The following is a description of a gene set: Human Gene Set: MIR524_5P from publication Chen Y, Wang X (PMID 31504780) Genes predicted to be targets of miRBase v22 microRNA hsa-miR-524-5p in miRDB v6.0 with MirTarget v4 prediction scores > 80 (high confidence targets). species: Homo sapiens, and this is the list of marker genes: PLEKHG1, FAM3C, CDH15, CCT7, ARFGEF3, RIF1, SUMO1, HS3ST3B1, MAPK6, TRDN, PDE10A, PSMB9, SMAD2, CTHRC1, SMC4, DNTTIP1, LIPA, UBE2D3, TUBB2B, RRAS2, SC5D, NRK, MED4 (mediator complex subunit 4), SEC24A, GOLGA6B, ARHGAP35, BSDC1, IGSF3, PTHLH, MECOM, ELK4, MAEL, WASHC4, SLC39A14, GIGYF2, NOP58, ANKRD44, MYF6, CHODL, SELENOF (selenoprotein F), DCAF7, WNK1, C11orf58, ST18, RNF182, CYP7B1 (cytochrome P450 family 7 subfamily B member 1), JAG1, RNF138, DCUN1D1, DLG2, TAF12, GBX2, ZBTB44, PLPPR4, PRPF39, TMEM215, ZNF772, CLNS1A, TMEM161B, GNB4, PPTC7, LRP12, ZNRF3, DGKE, SEC14L2, PPP3R1, JUN, MEIOC, STXBP5, FAM83B, CERT1, CERS6, HOXC8, HLCS, KDM6A, PLCB1, TSC22D2, SPRED1, ADAM23, DYRK1A, ZBTB7C, RBM26, GLS, UBE2Q2, FBXO45, MEAF6, PEX3, EDIL3, KIF1B, ARHGAP12, TAF8 (NCBI Gene Id 135763), PNN, GOLGA6C, CNOT8, TTC28, NEXMIF, AASDHPPT, RGCC, ANGPTL7, UBA6, HMGA2, SMURF2, FAM221A, SLITRK2, TXNL4B, KIF2A, GART, DLG5, NUP43, PRELID3B, LTN1, SMIM43, CNTNAP3, USF3, STAT4, MAPK1, VSIG10, L3HYPDH, RBL1, NXT2, CDK2, PCBP2, SIX4, RGS7BP, PKN2, ENPP4, TMEM196, DKK2, ATF2, BMP3, UBE2B, SGK3, CDC42BPB, RORA, SGIP1, CACNB2, ZMYM2, SCEL, TSHZ2, ITPR1, GRID2 (glutamate ionotropic receptor delta type subunit 2), GPC6, EPHA7, CEP350, BCL11B, SEC24B, PCDH9, CALB1, ACER2 (NCBI Gene Id 340485), ZCRB1, STXBP4, MPDZ, RBM27, HMGB3, CDH19 (cadherin 19), PRPF40A, MOSPD2, DHX40, TRAPPC13, FBXO32, SSB, PPP1R21, NFATC3, GSPT1, PHIP, GJB2, C17orf75, KLHL23, SHISA3, ATP2B2 (ATPase plasma membrane Ca2+ transporting 2), TBL1X, CNOT2 (CCR4-NOT transcription complex subunit 2), DDX17, RCAN2, SLC44A5, KLF4, SCN2A, USP53, LRP5, EML6 (NCBI Gene Id 649652), GRIN3A, ATMIN, HOOK3 (NCBI Gene Id 84376), EP400, TLCD4, GRM7, MRS2, EGLN1, PKDCC, ARPP19 (cAMP regulated phosphoprotein 19), OGA, MITF, APLN, DDX6, VIRMA, OLFM1, ELAPOR1, GPR180, ZNF827, ANO8, ZNF583, RHOT1, PHLDB1, RSBN1 (round spermatid basic protein 1), SRBD1, CEP120, GLRB, CCDC6, BCLAF1, RFC1, PREX2, ZBTB34, KAT6A, SLITRK6, LATS2, TAOK1, SLITRK4, TNKS2, PNISR, BRD4, FAM169A, HIRA, ARVCF, PARP8, NCOA1, KIN, E2F3, CAV2, SPTSSA, RBM39, ADGRL2, CPEB3, PPP5C, TBR1, LRRTM3, PRICKLE2, TMEM163, TMEM17, SCN3A, HOXB7, ZNF106, HCFC2, LUC7L2, FRMD6 (NCBI Gene Id 122786), PPM1L, IRX2, EGR1, FAM184A, YY1, RSPH4A, TFDP2, PELI2, ARHGAP33 (NCBI Gene Id 93092), MYOD1, SCAMP5, DDAH1 (dimethylarginine dimethylaminohydrolase 1), PRKCB, HSD17B13, ZMYND19, DIRAS2, FKBP14, SRSF10, PRKAB1, CSDE1, MGAT3, SESTD1, ZIC3, NUP37, TM4SF4, TSHZ1, MAP3K8, EGR4, YTHDC2, CIAO2A, SMAD3, IL1A, GOLGA8J, SOCS6, WIPF1, FAM13C, GIPC2 (GIPC PDZ domain containing family member 2), SLC1A2, YBX1, PTPN13, UBR5 (ubiquitin protein ligase E3 component n-recognin 5), COL4A1, DENND5B, ATP2B1, TMX4, PPP1R1B (NCBI Gene Id 84152), PRDX3, ARL13B, MIS18BP1, SEPSECS, CNTN1, ANKRD46, CCN1, SLC34A2, SLC6A6, DACH1, PLEKHF2, GNA13, DNAAF9, FAM76A, RNF220, TTN, GMFB, L3MBTL3, SULF1, NUDT4, BRD3, TMEM33, PIP5K1A, SPCS3, SLC30A6, NKRF, GORASP2 (golgi reassembly stacking protein 2), TAB2, HSF2, KIF5A, SMC3, SERPINB8, LRP8, TXNDC9, THOC3, PPP3CA, MEOX2, SPATA13, SCN8A, MLLT6, PER2, SIPA1L2, FKBP7, RAB6B, PAPOLG, CACNA2D2, ATAD2B (NCBI Gene Id 54454), ZMAT3, CNR1, MSS51, COL1A2, ACKR3, ZFC3H1, SULF2, CCNT2, FZD3, CYP20A1, RBFOX1, VAV3, COL11A1 (collagen type XI alpha 1 chain), LEF1, CBX3, APPL2, API5, PPFIA3, CPNE2, UBA3, OPA1, AKIRIN1, GOLGA8H, STK10, CHN2, PPP1R9A, CNRIP1, PBX1, AKAP11, MPRIP, PPP1R8 (protein phosphatase 1 regulatory subunit 8), MBNL1, GALNT7, HNRNPK, GPBP1, FBLN2, RNF216, SP3, ELAVL2, RPS6KA3, UBE2E3, STRBP, IFT70B, FGFR2, BMPR1A, MTM1, TMEM220, MAST4, RBBP5, MATCAP2, LHX6, ADAM10 (NCBI Gene Id 102), GOLGA8T, GDF10, RIN2, EED, GPM6A, RAB11A, HECTD1, CD46, SBF2, SORL1, TSNAX, CREB1, SLC25A13 (NCBI Gene Id 10165), CREM, GOLGA8R, MAP4K3, CDPF1, DCAF4L2, ZNF704, VPS13D (vacuolar protein sorting 13 homolog D), PNOC, NOVA1, GPR63, SOX8, ADCYAP1, ADAMTS5, ZMYND11, IMPA1, LAMC1, HSPA1B, HNF1B, NEBL, KPNA1, EBF2, SLC16A4, TMEM50A, ABRACL, H1-0, TRIP11, BHLHE40, MYRFL, RPS6KB1, SKIL, ARL5B, CHIC1, LIN9, SIRT1, PUS7, ZNF638, ZBTB43, GLUD1, ELOA, TRPS1, FZD2, BZW1, DICER1, ADAMTSL3, MAPK8, AZI2, TOM1L1, SRSF2, PRKRA, PSG1, MAMLD1, IKZF2, BCOR, SESN1, PPFIA1, KPNA4, KLHL28, ACSL3 (acyl-CoA synthetase long chain family member 3), DOCK1, TCF4, GNPTAB, RAI14, RAB14, TFRC, TCP11L2, CD1A, NEGR1, EOMES, SCAI, JMY, CENPC, CADM2, SUB1, SIPA1L1, FAM131A, NLGN4Y, AHCTF1, DOCK10, TOX, AJAP1, AR, PSIP1, SSNA1, NAV3, CGGBP1, SFPQ, TMEM170A, FCHO2, VAMP4, ITGB8, TPTEP2-CSNK1E, PLAGL2, PTPRE, FAM181A, ZNF716, ZNF711, SLC17A6, IGSF11, DENND2B, DLX4, APC, BRINP1, SLIT2, PTPRB, ZNF461, ARIH1, GFPT1, NUFIP1, PTPRU, PAFAH1B1, EFEMP1, DCAF10, CNTN5, TNFRSF19, MBD2, ARHGAP29, PFKFB3, PRIM2, ATP1A1, ACSL4, RAB12, LATS1, POC5, ERBIN, TBCCD1, COL3A1, REST, SMCHD1, NHS, SGMS1, ADK, SEH1L (NCBI Gene Id 81929), DMXL1, BUB1B, SLC38A2 (solute carrier family 38 member 2), SMNDC1, IQGAP2, TES, SUZ12, JARID2, LYPD6 (NCBI Gene Id 130574), ECT2, NSG1, RBM12, PKIA, TGFB3, ZNF516, CDC25C, MEGF9, ZMIZ1, DIP2A, TET2, NR4A2, PCDHB2, DUSP6, CASTOR2, LRBA, SELENOI, GPATCH2L, NAA50, TFEC, HOXA3, ZMYND8, HDAC2, TJP1, UGDH, VCAN, RBM23, ACTBL2, TFAP4, MTSS1, TLE4, RNF217, ELF1, PNRC1, SOX9, CREBRF, GNAI3, UBASH3B, MAP4K5, COX16, JAG2, ZFP36, MTTP, TMTC3, C1D, FBN1, PALS2, ETS2, CRTC1, TMF1, RALGPS2, ZFP36L1, UBR1, GOLGA6A, CAMTA1, GLI3, PDIK1L, SP4, POLR3B, SP8, USP7, RSBN1L, PPP6C, KCNC2, EFR3A, EPHA3, MAGEB6, HADHB, MFSD14A, DNAJC6, NKTR, FOXD3, SLC35D1, MLLT10, C1QTNF3 (C1q and TNF related 3), TAF4, TMED7, TRAPPC8, ACKR4 (NCBI Gene Id 51554), EID1, LRRC58, LARP1, ZSWIM4, CDK6, PTPRS, CALU, KLHL7 (NCBI Gene Id 55975), METTL9, DLX1, MEF2C, THSD7A, LMNB1, HIVEP2, TAFA1, CHAMP1, CCSER1, SV2A, EGFL6, TRIM23, NFYB, SORT1, INTS10, PTPRA, UBN2 (ubinuclein 2), OXSR1, UNC5C, APBA1, TTBK2, IL12B, TMEM30B, LACTB, IFT52, PHF20L1, MIB1, CEP57, ZEB2, SOX5 (SRY-box transcription factor 5), NFIA, ROBO1, BOD1L1, CETN3, PMS1, SERINC5, EYA1, DCX, IPMK, SLC4A7, DACT3 (NCBI Gene Id 147906), EPHA1, TAFA2, MSR1, FCGR2A, TMEM181, DRAM1, USP54, KCNK2, KIF21A, CLOCK, GOLGA8M, FAM76B, MTMR12, EBF3, PDZRN4, CDH4, RAP1B, IRF2, INO80D, HNRNPU, ADIPOR1, MBTPS1, LTA4H, PTH2R, PDCD10, PDE4B, CSMD1, GOLGA8Q, PEX5, SRD5A1, PAK5, NBEA, SYF2, DDHD1, VDR, PCGF6, SYT4, AZIN2, CWC25, LNX2, BDNF, GOLGA8A, CDH9, STK26, RAB33B, SS18, TMEM170B, KMT2C, ZYG11B, PUM1, PSPC1, SLC10A4, NANOS1, LRRC40, MIPOL1, SELENOS, ROR1, IRAK3, CACNA1D, MOK, EPC1, GOLGA8B, HEY1, RUFY2, PHLDB2, TMEM30A, SERPINB1, SCYL2, RP2, NWD2, ID4, NDUFS1, USP31, HIP1, SFSWAP, COX18, EPCAM, PCGF3, CRHBP, LSM8, CYTH2, C1QTNF7 (C1q and TNF related 7), VGLL3, MXD1, HS3ST3A1 (NCBI Gene Id 9955), APPBP2, RPRD1A, MYOF, HYCC2, KLF6, CD47, AGRN, PPM1A, SMARCAD1, ACTR3B, CLVS2, SOS1, KDM5A, CEBPD, SERF2, MMGT1, NPAT, AGFG1, NR2F1, DOCK4, WDFY3, RYR2, PTPN12, MAPK1IP1L, PGRMC1, GOLGA6D, EPHA5, ASB5, BEND4, CTTNBP2, WIPF3, CASP7 (NCBI Gene Id 840), KCNN4 (potassium calcium-activated channel subfamily N member 4), ITGA10, CLIC6, SMARCA2, NXPH2, PRNP, PLPP3, CNKSR2, PARP11 (NCBI Gene Id 57197), CILK1, CNOT6L, ASB13, CDC42, SPTY2D1, ZFR, CSNK1E, MYRF, ITM2C, CEP128, ANKRA2, ADAMTS16, SGK1 (NCBI Gene Id 6446), TEAD1, SECISBP2L, LMAN1, TRIO, CPPED1, RAP2C, ARHGEF33, USP25 (NCBI Gene Id 29963), EEIG2, LRP1B, SMPX, CACNA2D1, TENT4B, PALLD (NCBI Gene Id 51653), PELI1, SH3KBP1, RNF130, BNIP2, LARP4, BTBD7 (NCBI Gene Id 55727), GOLM2, RSRC2, ACBD5, C11orf54, YWHAQ, FBXO30, SAFB, ZMYM1, C1orf35, HEG1, SIAH1, CLLU1-AS1, HNRNPH1, EIF4E, ATP8A1, PLAGL1, RAB11B, C8orf44-SGK3, ZC3H12D (zinc finger CCCH-type containing 12D), HNRNPDL, OLIG2, G3BP2, CPEB2, PUM2, CDYL2, TTK, EPB41, ATAD5, OSTM1, STAU1 (NCBI Gene Id 6780), SLC25A12, MEOX1, BDH2, CAMK4, JAZF1, GATAD1, TCEAL1, TRA2A, TMEM39B, FOXJ3, RAP1GDS1, SMURF1, ATG2B, KAT2B, HEPACAM, GTF2A1, SLC30A4, ZNF655, HYCC1, BTAF1, GOLGA8N (golgin A8 family member N), B4GALT1, PTPRG, ARGLU1, ZNF367, HEY2, TWIST1, PSD3, INIP, GOLGA6L4, CLSTN1, FBXO3, PTX3, TXNIP, WDR43, AMFR, PROX1, CSMD3, ATXN1, LRRC3B, DIP2C, GID8, NUP205, ASH1L, GPT2, ATG16L2, IRAK2, HIPK1, TANK, FIBIN (NCBI Gene Id 387758), RANBP9, UNC13C, HS3ST1, PRKD3, OAT, CLK4, ZWILCH, SH3BGRL2, FOXO1, TAL1, WWC2, SLC40A1, GOLGA6L10, TCEA1, USP49, MINPP1, GABPA (NCBI Gene Id 2551), SLC22A10, E2F8, AP2B1, MAP3K5 (NCBI Gene Id 4217), GATAD2B, ACTA1, ADARB2, MSRB3, QKI (NCBI Gene Id 9444), TTC9, SYNJ2BP-COX16, INTS6, ESYT2, TCF7L2